Given this list of marker genes FBXO22, CDC6, CHAC2, MAT2B, RPGR, CYRIB, MTAP, ATG4A, S1PR2 (sphingosine-1-phosphate receptor 2), SLF2, GRIA3, VPS33B, DCTN6, POLR1F, YIF1A, UBA5, SS18L2, USP6NL, SNAPC1, SCP2, ARHGAP29, ARHGAP11A, RC3H2, SLC10A3, PPIP5K2, ARF6, SPAG9 (NCBI Gene Id 9043), GAS2L3, DACH2, INO80D, ERO1B, PLAC8, C10orf88, TRAPPC11, CHUK, GATA1, MAPK8, DDI2, GOLIM4, GPI, ASCC3, HOXD9, DNAJB11, DDX11, GSTM5, ABHD10, MTMR2, CTBP2 (C-terminal binding protein 2), KIAA1191, IMPDH2, GOT2, PIGB, LATS1, CHST11 (NCBI Gene Id 55807), POLR3A, KMT5B, AGL, NKRF, B4GALT1, TECPR2, BRMS1L, RBBP4, TBK1, BOD1L1, PAIP1, RP2, BLOC1S2, ATG2B, LTB4R, SUZ12, COPZ1, UBE2W, MCPH1, CUL4B, DAP, VPS35, SRPK1, RNPS1, SH3BGRL, SH3PXD2B, NUP35, TFRC, TMEM170B, FTX, PLEKHF1, VAMP4, FCER1G, MLX, ACTR6, CCDC34, KLRK1, CNMD, AGRN, ZBTB11, CSPP1, NDRG2, ZNF770, CBL, TMEM64, FOXD3, C1QBP, TBC1D24, RNF125, SEPHS2, MPHOSPH8, GNL3, ATP5F1C, CEP164, MTPAP, SSX2IP, AFG3L2, PECR, FBXO28, TRIP4, CCNQ, WSB2, HNRNPH3, RBX1, TUBA1B (tubulin alpha 1b), HSPA2, EIF4H, VAT1, HSP90B1 (heat shock protein 90 beta family member 1), MED4, ZNF141, ALG10, ZFAND1, NCOA2, SQOR, GNB1L, CCDC93 (coiled-coil domain containing 93), TLCD1, LMBRD1, SERAC1, CHCHD1, CDC73, DTWD1, ZFC3H1, IRAK4, EIF2B4, FAM76B, YBX3, GMFB, SDAD1, MDM1, FBRSL1, HADHB, IREB2, HNRNPUL2, USP33, VTI1B, MBD2, DCAF17, GORASP2, MAP3K2 (mitogen-activated protein kinase kinase kinase 2), TXNDC9, SRP9, SIVA1, ZBTB18, MTRES1, CCNYL1, TBL2, QKI (NCBI Gene Id 9444), ALAS1, FAM76A, SAT1, BCL2L2, GLOD4, PLK4, ZNF493, KCTD3 (potassium channel tetramerization domain containing 3), VPS26C, MOSPD2, RAPGEF6, UMAD1, TBC1D2B, RAB9A, ST6GALNAC4, PFKP, USP48, TCN2, KBTBD8, KMT2D, ZC3H7A, FCGR2B, RPUSD2, PARL, ERMP1, TRMT5, ZNF654, EDEM1, PKD2L2, CEMIP2, YIPF6, TMEM30A, LONRF1, G6PD, NDUFAF4, RSBN1, DBI, here is a description of the gene set: Primary HBE cells were stimulated with IL-22 and IL-17, and gene expression was studied using an Affymetrix platform microarray, in order to investigate which genes may be upregulated or downregulated in response to these cytokines. Of particular interest was the host defense genes such as antimicrobial peptides, which have been shown to be upregulated by IL-22 and IL-17 in skin keratinocytes. from publication Aujla SJ, Chan YR, Zheng M, Fei M, Askew DJ, Pociask DA, Reinhart TA, McAllister F, Edeal J, Gaus K, Husain S, Kreindler JL, Dubin PJ, Pilewski JM, Myerburg MM, Mason CA, Iwakura Y, Kolls JK (PMID 18264110) Genes up-regulated in primary bronchial epithelial cells stimulated with: IL22 versus IL17A. studied in species Homo sapiens Human Gene Set: GSE10240_IL22_VS_IL17_STIM_PRIMARY_BRONCHIAL_EPITHELIAL_CELLS_UP